Given this list of marker genes GJD2, GJA10, GJC1, PANX2, PANX1 (NCBI Gene Id 24145), here is a description of the gene set: Electrical transmission across nerve cells is accomplished when the current generated in the upstream neuron spreads to the downstream neuron through a path of low electrical resistance. In neurons this is accomplished at gap junctions. Electrical synapses are found in neuronal tissue where the activity of neurons must be highly synchronized. The neurons responsible for hormone secretion from the mammalian hypothalamus are a class of highly synchronized electric neurons. Gap junctions connecting the presynaptic cell with the postsynaptic cell allow current generated in the presynaptic cell to flow directly into the postsynaptic cell. Transmission speed is dramatically increased in such a system. The junction itself is composed of two hemichannels, one each on the pre- and postsysnaptic cells. These channels are composed of members of the connexin family of proteins. part of: Neuronal System Reactome Pathway: Transmission across Electrical Synapses species: Homo sapiens